Given this list of marker genes KCNK6, TNF, KL, NPPB, GPR37L1, NTSR1, MRGPRD, ADRB1, MIR17, TAC1, AGTR2, ADORA1, NPPA, BMPR2 (NCBI Gene Id 659), CRH, ADRB2, ADRA1A (adrenoceptor alpha 1A), ADRB3, IER3, SOD2, TAC4, PRCP, APLN, MAS1, BBS4, ARHGAP42, here is a description of the gene set: studied in species Homo sapiens Human Gene Set: GOBP_NEGATIVE_REGULATION_OF_SYSTEMIC_ARTERIAL_BLOOD_PRESSURE The process that reduces the force with which blood travels through the systemic arterial circulatory system.